Given this list of marker genes DRD5, GNA11, DRD4, DRD3, GNA14, NHERF1, DRD1, DRD2, here is a description of the gene set: Human Gene Set: GOBP_PHOSPHOLIPASE_C_ACTIVATING_DOPAMINE_RECEPTOR_SIGNALING_PATHWAY A phospholipase C-activating receptor G protein-coupled receptor signaling pathway initiated by dopamine binding to its receptor on the surface of a target cell, and ending with the regulation of a downstream cellular process, e.g. transcription. species: Homo sapiens